The following is a description of a gene set: Cafe-au-lait spots are hyperpigmented lesions that can vary in color from light brown to dark brown with smooth borders and having a size of 1.5 cm or more in adults and 0.5 cm or more in children. Cafe-au-lait spot Human Gene Set: HP_CAFE_AU_LAIT_SPOT species: Homo sapiens, and this is the list of marker genes: REV3L, WASF1, IGF1, BUB1B, SMARCA2, TRIP13, FANCE, CAPRIN1, HEPACAM, TSC2, TAF4, UBAP2L, FANCA, DHX30, RERE, MAP2K2 (mitogen-activated protein kinase kinase 2), EP300, MSH2, TOP3A, POLE, UBR1, FANCG, RBBP8, TMEM127, PLAG1, TWIST2, SKIC3, CLCN7, BUB3, CDKN1C, USF3, ABCB6, ESCO2, TMC8, PIK3CA, RET, AKT1, LZTR1, FANCB, COPB1, ARL6IP6, SLC9A1 (solute carrier family 9 member A1), IFNG, FANCC, RAF1, SDHD, MSH6, NBN, IRF1, IGF2, NF2, ERCC4, FANCL, SEC23B, SH3PXD2B, RFX7, UBE2T, RAD51C, KLLN, MAD2L2, CBL, XRCC2, PLXND1, BUB1, KDM5C, FANCI, PPP1CB, PDE11A, ATM, MED12, KANSL1, APC, MAX, FANCD2, HMGA2, CIB1, MTOR, BRIP1, PALB2, GNB2, SPRED1, PHIP, MAN1B1, SET, GNA11, SLF2, BRCA1, KDM6A, PCNT, PTPN11, MAPK1, BLM, TP63, PRKAR1A, CEP57, MEN1, RFWD3, FANCM, ABCC9, SLX4, KRAS, RAD51, MLH1, H4C5, PTEN, CWC27, SDHB, TSC1, BRCA2, SOX10 (SRY-box transcription factor 10), NRAS, TOMM7, SDHC, CHD8, FANCF, SHOC2, NF1, VHL, TMC6, KDM6B, BRAF, KMT2D, KITLG, WBP11, STEAP3, SKIC2, MAP2K1, PMS2, IL7, ANAPC1, CREBBP